Given this list of marker genes MRPL4, HNRNPAB, ISOC2, SPP1, CCT5, MRPS34, ADISSP, MRPS12 (NCBI Gene Id 6183), C1QBP, ALOX5AP, SNRPD1, PDCD5, DCTPP1, EIF5A, MRPL52, RRP7A, HSPD1, KCNN4, PPP1R14B, HSPA5, MANF, GGCT, CCT3, CCDC85B, CCT2, CCT6A, PPA1, FABP5, LDHB, PHB1, CORO1A, RANBP1, TOMM40, PA2G4, SRM (NCBI Gene Id 6723), NOP16, NHP2, MRPL12, NME1, EBNA1BP2, PSMC4, BOLA3, TIMM13, CLEC5A, APEX1, CYC1, ATP5MC1, PRMT1, MRPL3, SDF2L1, here is a description of the gene set: Genes upregulated in subsets of cells of a given type within various tumors Human Gene Set: GAVISH_3CA_METAPROGRAM_MACROPHAGES_MYC_MITOCHONDRIA studied in species Homo sapiens In this study, an extensive analysis was conducted to define meta-programs (MPs) capturing intra-tumor heterogeneity across a spectrum of tumor types. The approach utilized non-negative matrix factorization (NMF) to analyze each cell type separately within individual tumor samples. This involved the analysis of malignant cells, macrophages, fibroblasts, endothelial cells, epithelial cells, T-cells, and B-cells. NMF was executed with varying parameter values (K=4, 5, 6, 7, 8, 9), thereby generating 39 programs for each cell type per sample. Each NMF program was summarized by the top genes based on NMF coefficients.\nRobust MPs were then delineated for each cell type using a set of stringent criteria, including recurrence within the same tumor, similarity to programs in other tumors, and non-redundancy within a tumor. Subsequently, these robust NMF programs were clustered (per cell type) based on Jaccard similarity, leading to the identification of MPs associated with each cell type.\nTo enhance the quality of the MPs, a refinement steps were undertaken, involving the removal of MPs suspected of reflecting low-quality data (with an overrepresentation of ribosomal proteins or mitochondrial-encoded genes), single-study inclusion, or similarity to miss-annotated cell types. from publication Gavish A, Tyler M, Greenwald AC, Hoefflin R, Simkin D, Tschernichovsky R, Galili Darnell N, Somech E, Barbolin C, Antman T, Kovarsky D, Barrett T, Gonzalez Castro LN, Halder D, Chanoch-Myers R, Laffy J, Mints M, Wider A, Tal R, Spitzer A, Hara T, Raitses-Gurevich M, Stossel C, Golan T, Tirosh A, Suvà ML, Puram SV, Tirosh I (PMID 37258682)